Given this list of marker genes Mapk1, Mvk, Lss, Hmgcs2, Cftr, Lpcat3, 3110082I17Rik, Pex2, Sec14l2, Erlin1, Ces1e, Npc1l1, Hsd17b7, Ces1f, Apoa1, Pmvk, Ces1d, Fdft1, Prkaa1, Ces1g, Sqle, Mvd, Hmgcs1, Cyp7a1, Hmgcr (3-hydroxy-3-methylglutaryl-Coenzyme A reductase), Idi2, Ces1h (NCBI Gene Id 75704), Aqp8, Insig2, Ces1c, Abcg1, Msmo1, Npy1r, Insig1, Lipa, Faxdc2, Nsdhl, Srebf2, Paqr3, Cyb5r3 (NCBI Gene Id 97979), Gpr146, Mbtps2, Srebf1, Dhcr24, Idi1 (isopentenyl-diphosphate delta isomerase), Tm7sf2, G6pd2, Gnai1, Prkaa2, Erlin2, Scap, Fdps, Qki, Scp2, Ebp, Fgf1, Ch25h, Lbr, Dhcr7, Sc5d, G6pdx, Erg28, Abcg4, Cyb5r1, Cyb5r2, Apob (NCBI Gene Id 238055), Ces1b (carboxylesterase 1B), Por, Ces1a, Cyp51, Sod1, Prkaca, Apoe, here is a description of the gene set: Mouse Gene Set: GOBP_STEROL_BIOSYNTHETIC_PROCESS The chemical reactions and pathways resulting in the formation of sterols, steroids with one or more hydroxyl groups and a hydrocarbon side-chain in the molecule. studied in species Mus musculus